Given this list of marker genes PIBF1, HMGA2, DAB1, CAV1, NEUROD1, GBP7, NF2, SOCS1, INPP5F, HGS, PTPRC, VHL, PTPN2, CISH, MIR9-1, SOCS3, SH2B3, PTPRD, SOCS2, PARP14, LEPROT, MIR146A, ADIPOR1 (adiponectin receptor 1), BCL3, here is a description of the gene set: studied in species Homo sapiens Human Gene Set: GOBP_NEGATIVE_REGULATION_OF_RECEPTOR_SIGNALING_PATHWAY_VIA_JAK_STAT Any process that stops, prevents, or reduces the frequency, rate or extent of a receptor signaling pathway via JAK-STAT.